The following is a description of a gene set: Comprehensive identification of all functional elements encoded in the human genome is a fundamental need in biomedical research. Here, we present a comparative analysis of the human, mouse, rat and dog genomes to create a systematic catalogue of common regulatory motifs in promoters and 3' untranslated regions (3' UTRs). The promoter analysis yields 174 candidate motifs, including most previously known transcription-factor binding sites and 105 new motifs. The 3'-UTR analysis yields 106 motifs likely to be involved in post-transcriptional regulation. Nearly one-half are associated with microRNAs (miRNAs), leading to the discovery of many new miRNA genes and their likely target genes. Our results suggest that previous estimates of the number of human miRNA genes were low, and that miRNAs regulate at least 20% of human genes. The overall results provide a systematic view of gene regulation in the human, which will be refined as additional mammalian genomes become available. from publication Xie X, Lu J, Kulbokas EJ, Golub TR, Mootha V, Lindblad-Toh K, Lander ES, Kellis M (PMID 15735639) Human Gene Set: GATGKMRGCG_UNKNOWN studied in species Homo sapiens Genes having at least one occurrence of the highly conserved motif M148 GATGKMRGCG in the regions spanning 4 kb centered on their transcription starting sites. The motif does not match any known transcription factor binding site., and this is the list of marker genes: UBXN11, ISCU (iron-sulfur cluster assembly enzyme), FRY, ATF1, SPCS2, REXO1, GTF2H1, SLC10A7, DNM1, CACNA2D1, YWHAE, UBR5, CNOT3, HPS5, CIZ1, RNF26, LIMD1, HOXD12, YY1, CLSTN1, DPH1, C1QL2, STRN4, ZNRF2, FKRP, PCIF1, MORN4, NFU1, UBTF, DUSP6, SART3, IRAK1, PATZ1 (POZ/BTB and AT hook containing zinc finger 1, NCBI Gene Id 23598), PPP1R12B, SNX13, ZBTB22 (NCBI Gene Id 9278), TSC1, CCDC186, C21orf58, RPL7A, REM2, REPS2, WNT3 (NCBI Gene Id 7473), RAB22A, RBM5, PPP2R2A, EP300, PHF12, H3-3B, YWHAQ (tyrosine 3-monooxygenase/tryptophan 5-monooxygenase activation protein theta), RPL27, RBM3, RAD23A, NEUROD2, PTGR3 (NCBI Gene Id 284273), EIF5, PCNT, FHIP1B, MED1, MRPL38, RPL24, SUV39H2, TIA1, E2F3, MED22, EEF2